Given this list of marker genes DEDD, SLC25A46, UBXN11, ATP10A, ITIH3, ORAI1, ABRACL, UBR1, KCTD12, WHAMM, RCBTB2, ZBTB7A, TRHDE, YPEL5, DPF3, EPS8L1, FAM204A, GSAP, NMI, MGAT4A, FHIP2B, TGFBRAP1, ZBTB2, SECISBP2, PLAAT3, USP25, CLIC1, PLEC, SLC26A2, OSBPL9, ZNF205, MAN2A1, USE1, TRIM39, ATF2, NRAP, PRODH2, FAM120B, DRGX, WDR26, CTCF, AFP (NCBI Gene Id 174), NAA60, NDUFA1, MYO1E, PPP4R3B, THEMIS (thymocyte selection associated), MFSD8, RPLP2, SAT1, TRIM35, KMT2A, ARL2BP, CYB5D2, HMG20A (high mobility group 20A), PARP9, EIF1B, GRB7, SLC39A14, RAB2A, MTIF3, MAPK8IP2, MED28, RALGAPB, TBCA, BDH1, TRAF3, SUOX, THOC2, ADAMTS16, EI24, GPRIN3, CELF2, RER1 (retention in endoplasmic reticulum sorting receptor 1), MRAP2, SEMA3A, POU6F1, DHPS, ARID5A, SYAP1, STK38, SLX4, KBTBD2, SART1, CDON, CR1L, SPO11, PIAS4, SLC43A2, ATXN1L, MBOAT1, NCOA6, UBA1, PIGT (NCBI Gene Id 94004), SLC25A4, IRF2BPL, VPS37D, ZNF638, CCDC115, ETNK1, POLM, STAMBPL1 (NCBI Gene Id 57559), PSPN, CCDC88B, CDK17, OSBPL5, TENT5A, LIMD1, MYO1H, GIT2, WASHC2A, WASHC3, FASN, DERL2, FBXO25, UBE2B, ATP6AP1, NSMCE1, PTCD1, DAZAP2, CPSF3, TNKS2, CHMP1A, FPGT, NCK1 (NCK adaptor protein 1), TNFSF10, CD22, TNIP1, HSPB7, RARG, ZSWIM8, RNF146, CIPC, JARID2, GAS7, AQR, PGLYRP1, RALA, TRIP4, BICRA, KMT2D, ARHGAP25 (NCBI Gene Id 9938), TRAF3IP3, RGS14, HELZ2, RPTOR, MARVELD2, MYO9B, IRF7, ATP2A3, LGALS1, GADD45G, METTL3, CTNNBL1, DNAJC17, TAFAZZIN, AMBRA1, DDRGK1, CMIP, STX18, NABP1 (nucleic acid binding protein 1), DNMBP, PTTG1, HCLS1 (hematopoietic cell-specific Lyn substrate 1), ITGAV, SLC20A1, PTP4A2, CNOT2, TNFRSF1A, TAP1, RPAP2, TM6SF1, IFI35, GRHL3, KIN, HERPUD2, PRDM2, CXXC1, REX1BD, CAST, CYSLTR2, CRTC3, ITGAX, FYTTD1, CHKB, GSKIP, TTC17, MAP3K12, DGKZ, IL13RA1, INPP5E, ARGLU1, CYP2U1, SLC25A19, RIT1, SP1, IKBKE, HIGD2A, CCNDBP1, PPP1R12C, here is a description of the gene set: studied in species Homo sapiens Human Gene Set: GSE27786_LIN_NEG_VS_NKTCELL_DN Each fraction of mouse hematopoietic cells was purified by cell sorting from bone marrow of 8-week-old C57BL/6 mice, and its gene expression was analyzed. Genes down-regulated in comparison of lineage negative versus NKT cells. from publication Konuma T, Nakamura S, Miyagi S, Negishi M, Chiba T, Oguro H, Yuan J, Mochizuki-Kashio M, Ichikawa H, Miyoshi H, Vidal M, Iwama A (PMID 21540074)